Given this list of marker genes SFXN2, WNT2, ERBIN, GDF2, RAB36, PPP1R17, H3C14, STAT1, KCNC4, SPINK8, PARP11, RCN1, DCAF11, NUP214 (NCBI Gene Id 9680), TIMP4, TUBA4A, CLMN, SEMA4A, GORAB, COG5, ADGRG2, USP25, PLAGL2, BIRC3, GFAP, EPS8L2, SUGCT, PARP14, TMEM238L, DNAH8, RNF24, RTN1, GRPEL2, GRINA, ST8SIA4, CPEB2, GCFC2, WNK1 (WNK lysine deficient protein kinase 1), LXN, TTC21B, MAP7, PTBP2, ACLY, NCKAP1L, GFPT1, FAM13B, PAG1 (NCBI Gene Id 55824), UST, POGZ (NCBI Gene Id 23126), TSPYL5, BTG4, ASXL3, CCDC198, SLFN13, MAOB, DKK4, KCNK15, GBP7, TAGAP, DSE, CCR7, HARS1, GBP6, KBTBD2, TRIM25, CD74, TAPBP, MYO5B, ERAS, ZNF385A, ITGB1BP2, BTBD3, BCL6B, AHCYL1, CLDN6, FLVCR1, CLOCK, PNLIP, KIT, CPT1C, DTX3L, HTR7, ZNF184 (NCBI Gene Id 7738), INSM1, GAS2L2, CTSG, RIGI, IFNA1, TRPM7, ART5, HIVEP1, FBXO43, CRHR2, FAT3, CIPC, CPLANE1, REV1, EPHB1, UBC, TMEM229A, GSC2, LRRC39, USP46, NRIP3 (nuclear receptor interacting protein 3), ZNF280D (NCBI Gene Id 54816), DNAH5, HDAC1, BIRC2, DCLK3, LRRC58, NLRX1, PPP1R3D, IFIT2, ZNF655 (zinc finger protein 655), PRKD3, YIPF5, NR4A1, RRAGD, ASXL1, LEMD3, C10orf88, RAB21, ADGRG6, GCK, TRAT1, VPS13B, MEIG1, VPS54, TRPM1, PLCD3, YWHAG, FKTN, IL18BP, MOSPD2, REV3L, TSGA13, C16orf95, PPP2R1B, L1CAM, TPSG1, SCYL3, RBM48, SCIN, MXD1, PROSER2, CMA1, RANBP2, IL22, GNMT, KLHDC1, USF3, TJP1, COL14A1, RGS16, SNORD89, PPP6C, P2RY10, NABP1, CLTC, QRSL1, GRIA2, AHCYL2, RNF185, RND2, HIPK3, VCP, TLR3, MS4A6A, GTF3C2, KIAA1191, CATSPER2, AIFM3, PLS3, GRM4, DIAPH2, IRGM, TMEM140, ALAS2, STRN, DAO, SOS2, HTT, FOXN2, CAMSAP2, SCML2, INSL5, MAGED1, INCA1, PAPSS2, TBK1, CCL1, SPTA1, IFT80, ARHGAP20, ZBP1, CBLN1, MTHFR, SBSPON, PIGN, ZFP14, here is a description of the gene set: Nitric oxide (NO) produced by macrophages (MØs) is toxic to both host tissues and invading pathogens and its regulation is therefore essential to suppress host cytotoxicity. MØ arginase 1 (Arg1) inhibits NO production by competing with NO synthases for arginine, the common substrate of NO synthases and arginases. Two signal transduction pathways control Arg1 expression in MØs. First, a MyD88-dependent pathway induces Arg1 in intracellular infections, while a second Stat6-dependent pathway is required for Arg1 expression in alternativelyactivated MØs. We found that mycobacteria-infected MØs produce soluble factors that induce Arg1 in an autocrine-paracrine manner via Stat3. We identify these factors as IL-6, IL-10 and GCSF. We further establish that Arg1 expression is controlled by the MyD88-dependent production of IL-6, IL-10 and G-CSF rather than cell intrinsic MyD88 signaling to Arg1. Our data reveal the MyD88-dependent pathway of Arg1induction following BCG infection requires Stat3 activation and may result in the development of an immunosuppressive niche in granulomas due to the induced Arg1 production in surrounding uninfected MØs from publication Qualls JE, Neale G, Smith AM, Koo MS, DeFreitas AA, Zhang H, Kaplan G, Watowich SS, Murray PJ (PMID 20716764) Genes up-regulated in macrophages after M. bovis BCG infection: 24h versus 48h. studied in species Homo sapiens Human Gene Set: GSE22935_24H_VS_48H_MBOVIS_BCG_STIM_MACROPHAGE_UP